Given this list of marker genes Vcp, Ywhae, Eef1a1, Hsf1, here is a description of the gene set: part of: Cellular response to heat stress studied in species Mus musculus electronically inferred by orthology from the curated human pathway Reactome Pathway: HSF1 activation This event has been computationally inferred from an event that has been demonstrated in another species.<p>The inference is based on the homology mapping from PANTHER. Briefly, reactions for which all involved PhysicalEntities (in input, output and catalyst) have a mapped orthologue/paralogue (for complexes at least 75% of components must have a mapping) are inferred to the other species.